Given this list of marker genes FLT4, PTGER3, TRMT12, MBNL3, TFF3, WNK1, SLC18A2, CPNE3, BACH2, MRS2, ZBTB25, FAM8A1, FRAT2, RPS17P5, KRT2, MCPH1, ARHGEF6, ANK2, METAP1, TRIM46, HOXD13, SIRT5, CLCN6, GARNL3 (NCBI Gene Id 84253), KLHDC2, TSHB, TARBP1, TCFL5, TTLL1, RREB1, SS18L2, ZNF652, NAA16, BDH2, SEC24D, PRR5L, EGR2, NFATC3, GHSR, MCTS1, KDM5B, OSBPL3, PPP2R5A, EXD3, SLC25A14, SIRT4, SLC22A3, NTN3, KDM4A, PRL, PLSCR4, CROT, FBXL4, PTPN3, KLHL20, KRT19P2, GNG5, LEFTY2, CABIN1, SPP2, ZNF74, TMED9, TBC1D19, MAGEL2, GSTCD, PLA2G15, ZBTB7C, CEBPA, TPM1, GTF3A, OR2B2, TIPARP, DPY19L2P2, ATP7A, ZC2HC1A, METTL18, ARHGEF28, BCL9, GABRP, LETMD1, TPMT, CEP76, LRRC37A2, SLC25A12, HSP90B1, TRIM45, SAYSD1, CBFA2T3, PRR3, ATMIN (ATM interactor), KLF8, POU4F3, TAF4, ZBTB14, TSPAN12, SLC5A12, PLAG1, CYP11B1, SFN, FTL (ferritin light chain), ABHD5, PACSIN2, SLC44A4, SLIT2, ADGRG6, RASGRP3, NPY5R, ZNF510, DPH5, PLGRKT, MBP, MAP3K12, CDK13, XYLT1, ANP32A, LCE2B, CDADC1, PDZRN4, NKAPD1, ZKSCAN4, AURKC, ITGBL1, GPNMB, PEX11A, GLT8D1, ESM1, VPS53, MKRN1, TCP11, MFAP4, IFNA6, UGT8, NUP62CL, EXOG, TXLNG, THAP9, MRPL33, HRK, RAB27B, MLLT3, KLHL5, TBCE, SESN1 (NCBI Gene Id 27244), HAND1, RPL23AP32, TESK2, ARHGEF3, PIK3C2G, POLR1G, BTNL2, ZW10, GFI1B, NOL4, TOB1, CAMK2G, RAB31, NUAK1, PIP4K2A, MANBA, CAP1, RASAL1, APPL1, PER3, C4BPB, MARCHF8, ABCB1, RALBP1, RPL23AP7 (NCBI Gene Id 91036), ABHD17B, CFAP44, ARHGEF38, AGTR1, AMZ2, USH2A, TMEM223, PTGFR, SEC11A, ZFYVE21, PPT1, PCF11, TMEM70, SEPTIN2, LINC00339, PUDP, KIF13B, AGBL3, ITSN1, RPS15A, OSBPL1A, PPP2R5E, THRA, PCSK1, WRNIP1, SEC61A2, CD68, JARID2, RNF17, KBTBD4, STK39, here is a description of the gene set: Using whole-genome Affymetrix microarrays (HG-U133A), we characterized the transcriptome profile of cultured human macrophages stimulated for 4 h with interleukin 1 (IL-1) or interleukin 6 (IL-6). We found that, in distinction to liver cells, IL-1 is much more potent than IL-6 in modifying macrophage gene expression, although considerable heterogeneity in response of macrophages deriving from individual blood donors was observed. The obtained results permitted to identify a large number of cytokine-responsive genes. coding for proteins of unknown function that are now being studied in our laboratory. They may represent novel targets in the anti-inflammatory therapy. Human Gene Set: GSE8515_CTRL_VS_IL1_4H_STIM_MAC_UP from publication Jura J, Wegrzyn P, Korostyński M, Guzik K, Oczko-Wojciechowska M, Jarzab M, Kowalska M, Piechota M, Przewłocki R, Koj A (PMID 18498781) Genes up-regulated in comparison of untreated macrophages versus those treated with IL1. species: Homo sapiens